Given this list of marker genes Cav2, Veph1, Rbbp4, Nkx2-1, Tgfb3, Skil, Ltbp1, Ing1, Spred2, Hspa5, Adam17, Spred3, Pmepa1 (prostate transmembrane protein, androgen induced 1), Smad7, Nrros (negative regulator of reactive oxygen species), Dand5, Slc2a10, Spry2, Bmp2, Trp53, Vasn, Peg10 (paternally expressed 10), Sap30l, Snx25, Chst11, Brms1l (breast cancer metastasis-suppressor 1-like), Arid4b, Prdm16, Fbn1, Ints9, Arid4a, Ovol2, Onecut1, Sinhcaf, Adamtsl2, Htra1, Smad6, Rasl11b, Zfp451, Emilin1, Nepn, Spred1, Cdh3, Lemd3, Snx6, Lrp1, Cd109, Eid2, Snx1, Sin3a, Dnm2, Gdf15, Fam89b, Ski, Wfikkn1, Ryr1, Cilp (NCBI Gene Id 214425), Tgfbr3, Stub1, Sap130, Aspn, Ppm1a, Wfikkn2, Cripto (NCBI Gene Id 235635), Pparg, Pdpk1, Ppara, Il17rd, Lrrc32, Pbld2, Pin1rt1 (peptidyl-prolyl cis/trans isomerase, NIMA-interacting 1, retrogene 1), Sap30, Wnt1, Brms1, Hdac1, Tet1, Fkbp1a, Hdac2, Htra3, Pin1, Smurf2, Ogt, Onecut2 (one cut domain, family member 2), Ing2, Glg1, Smurf1, Pbld1, Cidea, Sirt1, Suds3, Bambi, Spry1, Ldlrad4, Strap, Bcl9l (B cell CLL/lymphoma 9-like), Fbn2, Zbtb7a, Skor2, Usp15, Rbbp7, Xbp1, here is a description of the gene set: species: Mus musculus Any process that stops, prevents, or reduces the frequency, rate or extent of any TGF-beta receptor signaling pathway. Mouse Gene Set: GOBP_NEGATIVE_REGULATION_OF_TRANSFORMING_GROWTH_FACTOR_BETA_RECEPTOR_SIGNALING_PATHWAY